The following is a description of a gene set: The process in which the migration of an axon growth cone of a retinal ganglion cell (RGC) is directed to its target in the brain in response to a combination of attractive and repulsive cues. species: Mus musculus Mouse Gene Set: GOBP_RETINAL_GANGLION_CELL_AXON_GUIDANCE, and this is the list of marker genes: Isl1, Vegfa, Robo2, Rpl24, Slit1, Ndp, Pou4f3, Zic2, Bmpr1b, Atoh7, Epha7, Ptprm, Efna5, Ephb1, Sema4f, Alcam, Nrcam, Slit2, Nrp1, Ephb2, Isl2, Pou4f2, Ephb3